Given this list of marker genes Pkib, Atr, Sgo2a, Tal1, Macroh2a1, Pml, Ptges3, Tnks, Lig4, Sirt6, Bub1, Ino80 (NCBI Gene Id 76476), Fen1, Ncapd2, Nabp2, Cdk2, Potefam3b, Atrx, Nvl, Rad50, Wrap53, Mapk3, Cct3, Gch1, Cct8, Ncaph2, Shcbp1l, Rad21, Naf1, Klf4, Slf2, Ino80c, Prkcq, Smc5, Yy1, Atm, Pot1a, Smc2, Terf2ip, Pnkp, Nbn, Uchl5, Kat5, Numa1, Potefam3a, Tcp1, Fbxo4, Ruvbl2, Tpr, Parn, Nek2, Mre11a, Terc, Tfpt, Ppp1r10, Ino80d, Ino80b, Mcrs1, Cct2, Hnrnpa2b1, Tinf2, Ruvbl1, Tnks2, Myc, Map3k4, Ctnnb1, Mapkapk5, Actl6a, Ddx11, Cct4, Cct7, Ncapd3, Aurkb, Dhx36, Actr8, Nek7, Ska1, Wnt3a, Pot1b, Ncapg2, Acd, Mad1l1, Cct5, Dkc1, Gnl3, Ncaph (non-SMC condensin I complex, subunit H), Ska3, Cdk1, Smc4, Actr5, Nfrkb, Terf2 (telomeric repeat binding factor 2), Ankrd66, Mapk15, Rtel1, Hmbox1, Xrcc5, Slx1b, Mad2l1bp, Ncapg, Nsmce2, Slx4, Slf1, Sfpq, Cct6a, Map2k7, Mapk1, Hnrnpd, Prap1, Terf1, Ercc1, here is a description of the gene set: Any process that activates or increases the frequency, rate or extent of chromosome organization. species: Mus musculus Mouse Gene Set: GOBP_POSITIVE_REGULATION_OF_CHROMOSOME_ORGANIZATION